Given this list of marker genes POLR2K, BRF1, BRF2, NFIC, POU2F1 (NCBI Gene Id 7823), GTF3C6 (NCBI Gene Id 112495), POLR1D, GTF3C5, POLR3F, NFIA, NFIB, SNAPC3, GTF3C4, SNAPC4, POLR2L, POLR3E, BDP1, GTF3C1, GTF3C2, POLR2F, POLR3D, POLR2H, SNAPC2, SNAPC1, POLR3H, POLR3A, NFIX, POLR3G, SSB, TBP, POLR3B, SNAPC5, POLR3K, GTF3C3, ZNF143, GTF3A, CRCP, POLR3C, POLR2E, POLR3GL, POLR1C, here is a description of the gene set: part of: Gene expression (Transcription) RNA polymerase III is one of three types of nuclear RNA polymerases present in eucaryotic cells. About 10% of the total transcription in dividing cells can be attributed to its activity. It synthesizes an eclectic collection of catalytic or structural RNA molecules, some of which are involved in protein synthesis, pre-mRNA splicing, tRNA processing, and the control of RNA polymerase II elongation, whereas some others have still unknown functions. Like other RNA polymerases, RNA polymerase III cannot recognize its target promoters directly. Instead it is recruited to specific promoter sequences through the help of transcription factors. There are three basic types of RNA polymerase III promoters, called types 1, 2, and 3. Although in vivo, RNA polymerase III may be recruited to these promoters as part of a large complex (holo RNA polymerase III) containing the polymerase and its initiation factors, in vitro the reaction can be divided into several steps. First, the promoter elements are recognized by DNA binding factors, which then recruit a factor known as TFIIIB. TFIIIB itself then directly contacts RNA polymerase III. In human cells but not in <i>S. cerevisiae</i>, there are at least two versions of TFIIIB. One contains TBP, Bdp1, and Brf1 (Brf1-TFIIIB), and the other TBP, Bdp1, and Brf2 (Brf2-TFIIIB). studied in species Homo sapiens Reactome Pathway: RNA Polymerase III Transcription